The following is a description of a gene set: Human Gene Set: HP_ABNORMAL_SCALP_MORPHOLOGY Abnormal scalp morphology Any anomaly of the scalp, the skin an subcutaneous tissue of the head on which head hair grows. studied in species Homo sapiens, and this is the list of marker genes: UBA2, RASA2, MAPRE2, USP8, SPOP, APC2, RPS15A, CRIPT, POLR3A, AARS1, TTC5, KDM1A, NELFA, DPH2, CDH3, CDK5, KCTD1, SMARCD1, AEBP1, PEPD, NECTIN4, MAP2K2, PRDM13 (PR/SET domain 13), FKRP, RPL26, ATRX, CTBP1, SETD5 (SET domain containing 5), KCNJ8, KCNH1 (potassium voltage-gated channel subfamily H member 1), CDK13, CBL, CCNK, NEPRO, RPS24, BRD4, FREM1, ACD, RPL15, TAF6, CPOX, MPLKIP, SPRED1, IPO8, SMARCA2, BANF1, SRY, APCDD1, NF1, SOX18, RPS26, LMNA, GDF6, ADARB1, NR3C1, SIN3A, LIPH, RBBP8, SOS1, SMO, UBE2A, LIG4, TRAIP, TCF12, WASHC5, LAMC2, CACNA1C, MBD5, IGF1R, SALL4, MED13L, GATA1, NSUN2, GMPPA (GDP-mannose pyrophosphorylase A), CDC42BPB, CNTNAP2, P4HA2, ZNF699, ANKRD11 (NCBI Gene Id 92821), SMC3, MID1, MMP1, ITGB6, SCNM1, PEX6, RNU12, GPR101, SVBP, MAP2K1, KDF1, NTRK1, FGD1, ARID2, SF3B4, ASH1L, FLI1, RNU4ATAC, ERCC3, RPS29, PIGG, FREM2, KIFBP, LZTR1, TP63 (tumor protein p63), KRT74, FIG4, POLR1C, PI4KA, RAF1, RHOBTB2 (Rho related BTB domain containing 2), SLC35C1, CHST3, ITGA3, BRCA1, BRAF, RPS19, XYLT2 (xylosyltransferase 2), RPL31, RPL35, RPL21, HLA-DRA, MAFB, MGAT2, ZIC1, KDM4B (NCBI Gene Id 23030), LAMA3, FRAS1, TSPEAR, RPS27, JARID2, CAPRIN1, RPS7, CREBBP, COL17A1, EP300, JUP, ERI1, PCNT, VPS51, SPEN, SMC1A, MADD (MAP kinase activating death domain), SOS2, SRCAP, SHOC2, RTEL1, PKP1, ARID1B, MBTPS2 (membrane bound transcription factor peptidase, site 2), KRT25, BICRA, FGFR3, ADAM17, TWIST1, ASCC3, RHOA, DCLRE1B, PHF8, UROD, FGFR2, HUWE1, H4C5, ALDOA, TECPR2, PRKD1, EFEMP1, LMX1B, HTRA1, MEIS2, TBX2, CWC27, IGF1, TWIST2, UBAP2L, WBP11, MAN2B1, SLC12A6, NFKBIA, RPL11, RIPK4, FAT4, DOCK7, SLC9A7, B3GALT6, GTF2E2, NUP85, VPS33A, SLC26A2, CCDC22, GDF3, SLC39A4 (solute carrier family 39 member 4), RAD21, ERCC2, CHN1, THOC6, DCLRE1C, KREMEN1, KNSTRN, ALG9, RPS17, CIT, EMC1, B4GALT7, TINF2, B3GAT3, AFG2B, DHX30, ATP6V1B2, PACS1, TBX15, SLCO2A1, SETD2, GJB2, FLNA, HLA-DRB1, DPH1, PTDSS1, RRAS2, APC, KRT17, DNA2, ADNP, HNF1B, FAS, PARN, ATR, EDARADD, TP53, POLR1D, ZFX, CLCN3, POLR1B, EPS8L3, IFT140 (NCBI Gene Id 9742), SMARCC2, NAA80, CENPE, HDAC8, STAG2, AHSG, PPP1CB, ACTG1, TARS1, MED25, RPS20, TMCO1, NBN, TCOF1, FRMD4A, DLX4, KAT6B, RPL27, DPM2, DPF2, EFNB1, COL18A1, RALGAPA1, CNOT3, FILIP1, USB1, SPINK5, NOTCH2, PIGK, USP48, ATRIP, MYH3, MED12 (mediator complex subunit 12), XRCC4, TBC1D24, UBR1, HEATR3, CDH23, WNT10A, KANK2, TTC7A, ARID1A, UROS, HR, HS2ST1, ITGB4, KDM6A, ECM1, MRAS, PTPN11, LSS, ALX3, ALG11, NHP2, WLS, EBF3, TFAP2A, SMARCB1, MEGF8, ARHGEF2, ZBTB20, KMT2D, CEP152, SOX4 (SRY-box transcription factor 4), NANS, DOCK6, SNRPE (small nuclear ribonucleoprotein polypeptide E), SLC25A24, DSC3, LETM1, RBL2, ABCC9, INTU, MEOX1, COL7A1, SATB1, TRPS1, CAV1, RPS28, CARS1, DSG4 (NCBI Gene Id 147409), LAMB3, KRAS (NCBI Gene Id 3845), MAPK1, GDF11, KCNN3, UGP2, RIT1, RPS10, GNE, RECQL4, AGPAT2, CDH1, SOX11, GTF2H5, H1-4, TSR2, PPARG, ASXL1, CDSN, ANTXR1, CLDN1, PPP1R13L, ADA2, EBP, RRAS, TSC1, IRX5, PEX1, CAVIN1, PIGA, LRPPRC, EDEM3 (ER degradation enhancing alpha-mannosidase like protein 3), LPAR6, TRMT10A, DEAF1, SH2B1, C3orf52, TERT, PPP1R15B, RNF113A, EXT1, RAB3GAP1, VPS13B, COL3A1, NDE1, IFIH1, COG5, ALX1, PGAP1, SMARCA4, ACTB, EIF5A, ALG12, LTV1, HSPG2, MAF, GJB6, NIPBL, HLA-B, HPGD, ALX4, RERE, ZC4H2, RPL5, VAC14, AXIN2, HYOU1, KMT2A, GNB2, WNT4, CTCF, COG7, PIK3CD, RPL18, SPECC1L, AIFM1, GJA1, PEX19, INSR, RPL35A, NOVA2 (NCBI Gene Id 4859), PLEC, LRP2, HRURF, OCRL, CHRNG, CBS, SLC27A4, KLHL24, STT3A, SYT1, ANKRD17, CST6, MAP3K7, RIN2, MYO18B, PTPN22, NOP10, RAB18, FGFRL1, RPL9, MSX2, KRT14, NOTCH3, NSD2, ERMARD, BSCL2, FOS, MAB21L1, NUDT2, NRAS, RAB3GAP2 (RAB3 GTPase activating non-catalytic protein subunit 2), SASH1, TBL1XR1, CPLX1, WRN, H3-3A, CDH2, PCGF2, NFIX, TBC1D20 (NCBI Gene Id 170488), TRIO, ARX, RPL8, HDAC4, DKC1, SMPD4, SMARCE1, PLK4, SPRED2, AIP, SLC29A3, ODC1, NSD1, TRPM3, PIK3C2A, EGFR